Given this list of marker genes Nog, Prrt2, Syt7, Ncstn, Chrd, here is a description of the gene set: studied in species Mus musculus Mouse Gene Set: GOBP_SHORT_TERM_SYNAPTIC_POTENTIATION The process by which synaptic transmission, induced by the arrival of a spike (action potential) at a synapse, acts to increase the amount of neurotransmitter released in response to the arrival of subsequent spikes. This effect is seen when a train of closely space spikes arrives at a synapse with a low initial release probability. It occurs in a timeframe of tens to hundreds of milliseconds.